Given this list of marker genes Ankrd33b, Vmn1r58, Pdgfra, Tent5a, Pias2, Rnasel, C130050O18Rik, Ammecr1, Itk, Caln1, Cnpy1, Grk4, Akr1c13, Ophn1, Mob2, Naa50, Snupn, Snrpf, Tex24, Krtap5-4, Phyhd1, Terf2ip, Cep57l1 (centrosomal protein 57-like 1), Kcna6, Tmed8, Aim2, Zhx1, Parp6, Mboat4, Pag1, Lep, Flt3, Naca, Sin3a, Rexo4, Khdrbs3, Tbr1, Lrp8, Cd200r4, Rnf112, Plag1, Spn, Arl15, Unc93b1 (NCBI Gene Id 54445), Ahctf1, Mob3c, Unc5d, Slc35f3, Dhx58, Nmrk2, Lpgat1, Ric3, Olfm1, Cd3e, Astn2, Clcn5, Zfr, Atp6v0c, Atxn1l, Btg1, Syndig1, Sgpp2, Kcnj9, Btg1c, Wnt5b, Kank2, Rbm17, Slx4ip, Haus6, Adam28, Hspa12a, here is a description of the gene set: Genes predicted to be targets of miRBase v22 microRNA mmu_miR_7007_3p in miRDB v6.0 with MirTarget v4 prediction scores > 80 (high confidence targets). from publication Chen Y, Wang X (PMID 31504780) Mouse Gene Set: MIR_7007_3P studied in species Mus musculus